Given this list of marker genes PRKAA1, CAPRIN1, UBAP2L, BECN1, PRKAA2, STYXL1, ATG5, USP10, HSF1, here is a description of the gene set: studied in species Homo sapiens Any process that modulates the rate, frequency or extent of stress granule assembly, the aggregation, arrangement and bonding together of proteins and RNA molecules to form a stress granule. Human Gene Set: GOBP_REGULATION_OF_STRESS_GRANULE_ASSEMBLY